The following is a description of a gene set: species: Mus musculus Mouse Gene Set: GOBP_LYMPH_VESSEL_MORPHOGENESIS The process in which the anatomical structures of lymph vessels are generated and organized. The lymph vessel is the vasculature carrying lymph., and this is the list of marker genes: Ppp3cb, Acvrl1 (NCBI Gene Id 11482), Acvr2b (NCBI Gene Id 75114), Ptpn20, Prox1, Flt4, Fgf2, Ccbe1, Lgals8, Nfatc1, Tie1, Bmpr2, Ptpn14, Epha2, Sox18, Clec14a, Vegfa, Pdpn, Vash1, Vegfc, Ngp, Pkd1, Svep1, Foxc1, Foxc2